Given this list of marker genes Ovol2 (NCBI Gene Id 69059), Pou2f3, Scrt1, Hoxa9, Nalf2 (NCBI Gene Id 620592), Skor1, Gsx2, Hoxb9, Kcna7, Ryr2, Grin1, Cabp7, Tmem150c, Pgbd5, Tcerg1l, Kcns2, Kctd8, Npas2, Gfi1, Fgf3, Atp12a, Tlx3, Slc6a3, Tlx1, Syne3, Sim2 (single-minded family bHLH transcription factor 2), Srcin1, Crtac1, Rxrg, Hoxa13, Stac2, Ppm1n, Prph, Fstl4, Pou4f3, Ikzf3, Bhlhe23, Kcnq1, Hoxb3, Ghsr, Rspo1, Hoxb8, B3gnt7, Slc12a5, C1ql2, Penk, Foxn4, Ptprn, Ajm1, Tmem163, Rasgef1c, Tbx21, Kcnk6, Stmn2, Pappa, Hoxb5, Igfbpl1, Pitpnm3, Gabra5, Syt2, Hoxb7, Scn5a, Adgrb1 (adhesion G protein-coupled receptor B1), Six6, Npas1, Lad1, Slc6a20a (NCBI Gene Id 210451), Il11 (interleukin 11), Serinc2, Neurod2, Tmem130, Vgll2, Hoxd11, Nptxr, Hr, Msc, Cplx1, Nell1, Ucn, Cdh1, Hs3st6, Rab11fip1, Sox18, Nkx2-1, Slc22a3, Drd2, Cimip3, Hoxc8, Sptbn2, Sowahb, Kcnk3, Bmp6, Npr3, Hrh3, Car7, Fgf4, Eif4e3, Cadm3, Wnt9b, Ly6h, Prokr2, Fgf14, Igf2bp1, Car10, Mal, Slc7a14, Dmbx1, Col14a1, Syt12, Galr3, Kcnq2, Chrna4, Adra2c, Onecut3, Epha8 (Eph receptor A8), Plk5, Ankrd63, Lrrc26, Foxl1, Pitx1, Aldh1a2, Fbll1, Foxb2, Pyy, Wnt10a, Tmem151a, Col15a1, Shisa6, Ltbp2, Cdx2, Cpne5, Bnc1, Emx1, Stbd1, Flt3, Mal2, Gata5, Calcr, Ikzf1, St8sia6, Zfp536, Dmrt3, Cnnm1, Atp2b2, Lin28a, Htr1a, Prdm16, Gsx1, Pax7, Hcn2, Nkx2-3, Pdgfb, Ihh, Hoxd10, Hes2, Rab37, Colec12, Cldn7, Tmem91 (NCBI Gene Id 320208), Slc9a2, Sp8, Trp73, Hoxb4, Vwa2, Sall4, Grik3, Abcg1, Lsr, Trpc6, Prok2, Wnt4, Slc38a4, Foxd3, Mpped1, Ripk4, Dbx1, Mesp1, Wnt1, Grm7, Hoxb1, Bnc2, Cacna2d2, Isl1, Cyp2s1, Hoxc9, Pth1r, AI661453, Prkcz, Crb3, Rap1gap2, Eva1a, Amigo2, Vdr, Lipg, Llgl2, Lbx1, Slc17a6, Dpp10, Hoxb2, Vsx1, Dlgap2, Rprml, Cryba2, Lhx8, Col13a1, Fev, Htr7, Jph3, Evx2, Ffar4, Mixl1, Otp, Scube1, Rbfox3, Slc30a3 (NCBI Gene Id 22784), Tnfrsf11a, Pax3, Nefh, Phlda2, C1qtnf4, Rtn4r, Dmrt2, Spint1, Cdh8, Snhg11, Iqsec3, Lrat, Lemd1 (NCBI Gene Id 98340), Ralyl (RALY RNA binding protein-like), Fibcd1 (NCBI Gene Id 98970), Prxl2b, Clstn2, Dact2, Gjd2, Sigirr, Foxg1, Degs2, Alk, Dlx3, Jag2, Pdx1, Snai3, Hcrtr1, Sfrp1, Sorcs3 (sortilin-related VPS10 domain containing receptor 3), Sgpp2, Grin2b, B4galnt2, T, Fam43b, Cbln4, Gabrg3, Scn4b (sodium channel, type IV, beta), Hcn1, Alx3, Celsr1, Cxcl14, Hck, Slc6a5, Hoxc10, Hoxc6, Igsf21, Utf1, St8sia3, Chat, Cckbr, Plxdc1, Tfap2b, Sult4a1, Scnn1g, Tmem132e, Skap1, Dmrt1, Dscaml1, Slco4c1, Fam167a, Ovol1, Tnfrsf1b, Galnt13, Pax1, Cartpt, A330008L17Rik, Slit2, Ptf1a, Tdrp, Wnt3a, Ecel1, Jhy, Alx1, Fezf2 (NCBI Gene Id 54713), Evx1, Kcns3, Cobl, Ppp2r2c, Gpr27, Nlrp6, Hecw1, Fam89a, Map3k21, Fam163b, Hpcal4, Neurog3, Ccdc92b, Igf2, Lmx1a, Mast1, Ptprt, Lrfn5, Hoxd9, Nxph2, Vax1, Otop1, Dock8, Kcnh1, Vipr1, Cntn2, Nfatc2, Slc6a17, Hoxc13, Tfap2c, Hoxa11, Cyp26a1, Foxe3, Tbx3, C1ql1, Vat1l, Pgr (progesterone receptor), D930020B18Rik, Nkx6-1, Cpz, Bmp4, Sfrp5, Uncx, Crhr1, Oprd1, Lhx5, Pou4f2, Phf24, Rab11fip4, Tcf15, S1pr5, Sim1, Gjb2, Bcl11a, Irf5, Gpr37, Tfap2d, here is a description of the gene set: Mouse Gene Set: MIKKELSEN_NPC_HCP_WITH_H3K27ME3 from publication Mikkelsen TS, Ku M, Jaffe DB, Issac B, Lieberman E, Giannoukos G, Alvarez P, Brockman W, Kim TK, Koche RP, Lee W, Mendenhall E, O'Donovan A, Presser A, Russ C, Xie X, Meissner A, Wernig M, Jaenisch R, Nusbaum C, Lander ES, Bernstein BE (PMID 17603471) Genes with high-CpG-density promoters (HCP) bearing histone H3 trimethylation mark at K27 (H3K27me3) in neural progenitor cells (NPC). species: Mus musculus We report the application of single-molecule-based sequencing technology for high-throughput profiling of histone modifications in mammalian cells. By obtaining over four billion bases of sequence from chromatin immunoprecipitated DNA, we generated genome-wide chromatin-state maps of mouse embryonic stem cells, neural progenitor cells and embryonic fibroblasts. We find that lysine 4 and lysine 27 trimethylation effectively discriminates genes that are expressed, poised for expression, or stably repressed, and therefore reflect cell state and lineage potential. Lysine 36 trimethylation marks primary coding and non-coding transcripts, facilitating gene annotation. Trimethylation of lysine 9 and lysine 20 is detected at satellite, telomeric and active long-terminal repeats, and can spread into proximal unique sequences. Lysine 4 and lysine 9 trimethylation marks imprinting control regions. Finally, we show that chromatin state can be read in an allele-specific manner by using single nucleotide polymorphisms. This study provides a framework for the application of comprehensive chromatin profiling towards characterization of diverse mammalian cell populations.